Given this list of marker genes P2RY4, P2RY6, BEST1, OSTM1, CLCN7, SLC26A6, CLCNKB, SLC12A2, CLCNKA, here is a description of the gene set: Human Gene Set: GOBP_TRANSEPITHELIAL_CHLORIDE_TRANSPORT The directed movement of chloride ions from one side of an epithelium to the other. species: Homo sapiens